Given this list of marker genes LAMA2, PYGL, MLIP, PFKM, LAMP2, CAV3, SLC16A1, DPYS, RYR1, PYGM (glycogen phosphorylase, muscle associated), HINT1, PGAM2, CHCHD10, DMD, PGK1, ATP2A1, CPT2, here is a description of the gene set: Human Gene Set: HP_EXERCISE_INDUCED_MUSCLE_CRAMPS Exercise-induced muscle cramps Sudden and involuntary contractions of one or more muscles brought on by physical exertion. studied in species Homo sapiens